The following is a description of a gene set: species: Homo sapiens A process that is carried out at the cellular level which results in the assembly, arrangement of constituent parts, or disassembly of PML bodies, a class of nuclear body; they react against SP100 auto-antibodies (PML = promyelocytic leukemia). Human Gene Set: GOBP_PML_BODY_ORGANIZATION, and this is the list of marker genes: SUMO1, HIPK2, HABP4, ETS1, PML, SERBP1, SUMO1P1